Given this list of marker genes APOD, CCDC80, C7, CFH, RARRES1, MGST1, CXCL12, GSN, SERPINF1 (NCBI Gene Id 5176), GPX3, CXCL14, MT1X, SOD3, PI16, CFD, CCN5, IGF1, FMO2, ITM2A, SRPX, SFRP1, SFRP2, GPC3, PTGDS, TXNIP, FBLN1, MFAP5, SELENOP, ADH1B, FGF7, PODN, APOE, COL14A1, GPNMB, EFEMP1, SPARCL1, SFRP4, PRELP, IGFBP6, C3, PLAC9, OGN, CLU, FBLN5, MGP, DPT, ABCA8, PLA2G2A, MFAP4, TNXB, here is a description of the gene set: Human Gene Set: GAVISH_3CA_METAPROGRAM_FIBROBLASTS_COMPLEMENT Genes upregulated in subsets of cells of a given type within various tumors In this study, an extensive analysis was conducted to define meta-programs (MPs) capturing intra-tumor heterogeneity across a spectrum of tumor types. The approach utilized non-negative matrix factorization (NMF) to analyze each cell type separately within individual tumor samples. This involved the analysis of malignant cells, macrophages, fibroblasts, endothelial cells, epithelial cells, T-cells, and B-cells. NMF was executed with varying parameter values (K=4, 5, 6, 7, 8, 9), thereby generating 39 programs for each cell type per sample. Each NMF program was summarized by the top genes based on NMF coefficients.\nRobust MPs were then delineated for each cell type using a set of stringent criteria, including recurrence within the same tumor, similarity to programs in other tumors, and non-redundancy within a tumor. Subsequently, these robust NMF programs were clustered (per cell type) based on Jaccard similarity, leading to the identification of MPs associated with each cell type.\nTo enhance the quality of the MPs, a refinement steps were undertaken, involving the removal of MPs suspected of reflecting low-quality data (with an overrepresentation of ribosomal proteins or mitochondrial-encoded genes), single-study inclusion, or similarity to miss-annotated cell types. from publication Gavish A, Tyler M, Greenwald AC, Hoefflin R, Simkin D, Tschernichovsky R, Galili Darnell N, Somech E, Barbolin C, Antman T, Kovarsky D, Barrett T, Gonzalez Castro LN, Halder D, Chanoch-Myers R, Laffy J, Mints M, Wider A, Tal R, Spitzer A, Hara T, Raitses-Gurevich M, Stossel C, Golan T, Tirosh A, Suvà ML, Puram SV, Tirosh I (PMID 37258682) species: Homo sapiens